The following is a description of a gene set: Binding to a ferrous iron ion, Fe(II). species: Homo sapiens Human Gene Set: GOMF_FERROUS_IRON_BINDING, and this is the list of marker genes: ALKBH2, ACP5, ISCU (iron-sulfur cluster assembly enzyme), ALKBH3, EGLN3, FTO, DNAJC24, SNCA, EGLN1, CDO1, HAAO, FTH1, FTHL17 (ferritin heavy chain like 17), ALKBH1, FXN, FTMT, FTL, EGLN2, FTH1P19, FECH, HIF1AN, TF, DPH3, TET2, PHYH (phytanoyl-CoA 2-hydroxylase)